The following is a description of a gene set: Any process that modulates the frequency, rate, or extent of dendritic cell antigen processing and presentation. studied in species Homo sapiens Human Gene Set: GOBP_REGULATION_OF_DENDRITIC_CELL_ANTIGEN_PROCESSING_AND_PRESENTATION, and this is the list of marker genes: NOD1, CD74, CCL19, CD68, CCR7, FGL2, CCL21, NOD2, FCGR2B, SLC11A1, THBS1